Given this list of marker genes Rbp4, Flvcr2, Flvcr1, Stra6, Slc44a2, Slc44a1, Abcc4, Stra6l, here is a description of the gene set: Mouse Gene Set: GOMF_ALCOHOL_TRANSMEMBRANE_TRANSPORTER_ACTIVITY studied in species Mus musculus Enables the transfer of an alcohol from one side of a membrane to the other. An alcohol is any carbon compound that contains a hydroxyl group.